The following is a description of a gene set: studied in species Homo sapiens Human Gene Set: GOMF_RIBOFLAVIN_TRANSMEMBRANE_TRANSPORTER_ACTIVITY Enables the transfer of riboflavin from one side of a membrane to the other. Riboflavin (vitamin B2) is a water-soluble B-complex vitamin, converted in the cell to FMN and FAD, cofactors required for the function of flavoproteins., and this is the list of marker genes: SLC52A3 (NCBI Gene Id 113278), RTBDN, SLC52A2, SLC52A1, SLC22A14, ABCG2